Given this list of marker genes POLE2, PRPF19, ERCC8, ERCC1, POLR2K, COPS6, POLR2L, POLR2F (NCBI Gene Id 5435), XAB2, COPS7A, GTF2H2, UBC, UBA52, RPA2, POLK, PPIE, UBB, POLR2C, PCNA, GTF2H4, POLE3, POLR2J, GTF2H5, RFC4, LIG3, XPA, GPS1, POLR2B, ERCC6 (ERCC excision repair 6, chromatin remodeling factor), CCNH (NCBI Gene Id 902), ERCC2, POLR2I, POLD1, CUL4A, RPA1, POLR2A, POLE, RFC3, MNAT1, RFC5, TCEA1, UVSSA, GTF2H3, AQR, POLR2G, ZNF830, ERCC5, ISY1, RPA3, CUL4B, GTF2H1, ELL, COPS2 (COP9 signalosome subunit 2), ERCC3 (ERCC excision repair 3, TFIIH core complex helicase subunit), COPS3, POLR2E (NCBI Gene Id 5434), POLD4, ERCC4, RFC1, COPS5, LIG1, POLD2, COPS8, POLE4 (DNA polymerase epsilon 4, accessory subunit), POLR2D, RPS27A, RFC2, RBX1, COPS7B, DDB1, USP7, POLR2H, XRCC1, CDK7, COPS4, POLD3, here is a description of the gene set: Reactome Pathway: Transcription-Coupled Nucleotide Excision Repair (TC-NER) species: Homo sapiens part of: Nucleotide Excision Repair DNA damage in transcribed strands of active genes is repaired through a specialized nucleotide excision repair (NER) pathway known as transcription-coupled nucleotide excision repair (TC-NER). TC-NER impairment is the underlying cause of a severe hereditary disorder Cockayne syndrome, an autosomal recessive disease characterized by hypersensitivity to UV light.<BR>TC-NER is triggered by helix distorting lesions that block the progression of elongating RNA polymerase II (RNA Pol II). Stalled RNA Pol II complex triggers the recruitment of ERCC6. ERCC6, commonly known as CSB (Cockayne syndrome protein B) recruits ERCC8, commonly known as CSA (Cockayne syndrome protein A). ERCC8 has 7 WD repeat motifs and is part of the ubiquitin ligase complex that also includes DDB1, CUL4A or CUL4B and RBX1. The ERCC8 ubiquitin ligase complex is one of the key regulators of TC-NER that probably exerts its role by ubiquitinating one or more factors involved in this repair process, including the RNA Pol II complex and ERCC6.<BR>In addition to RNA Pol II, ERCC6 and the ERCC8 complex, the transcription elongation factor TFIIH, which is also involved in global genome nucleotide excision repair (GG-NER), is recruited to sites of TC-NER. The TC-NER pre-incision complex also includes XPA, XAB2 complex, TCEA1 (TFIIS), HMGN1, UVSSA in complex with USP7, and EP300 (p300). XPA probably contributes to the assembly and stability of the pre-incision complex, similar to its role in GG-NER. The XAB2 complex is involved in pre-mRNA splicing and may modulate the structure of the nascent mRNA hybrid with template DNA through its RNA-DNA helicase activity, allowing proper processing of DNA damage. TCEA1 may be involved in RNA Pol II backtracking, which allows repair proteins to gain access to the damage site. It also facilitates trimming of the 3' end of protruding nascent mRNA from the stalled RNA Pol II, enabling recovery of RNA synthesis after repair.<p>Deubiquitinating activity of the UVSSA:USP7 complex is needed for ERCC6 stability at repair sites. Non-histone nucleosomal binding protein HMGN1 and histone acetyltransferase p300 (EP300) remodel the chromatin around the damaged site, thus facilitating repair.<p>Dual incision of the lesion-containing oligonucleotide from the affected DNA strand is performed by two DNA endonucleases, the ERCC1:ERCC4 (ERCC1:XPF) complex and ERCC5 (XPG), which also participate in GG-NER. DNA polymerases delta, epsilon or kappa fill in the single stranded gap after dual incision and the remaining single strand nick is sealed by DNA ligases LIG1 or LIG3 (the latter in complex with XRCC1), similar to GG-NER. After the repair of DNA damage is complete, RNA Pol II resumes RNA synthesis.<BR>For past and recent reviews, see Mellon et al. 1987, Svejstrup 2002, Hanawalt and Spivak 2008, Vermeulen and Fousteri 2013 and Marteijn et al. 2014.